The following is a description of a gene set: studied in species Homo sapiens from publication Chen Y, Wang X (PMID 31504780) Human Gene Set: MIR4772_5P Genes predicted to be targets of miRBase v22 microRNA hsa-miR-4772-5p in miRDB v6.0 with MirTarget v4 prediction scores > 80 (high confidence targets)., and this is the list of marker genes: KBTBD4, ABT1, GAS2L3 (NCBI Gene Id 283431, growth arrest specific 2 like 3), FOS, SV2B, SLITRK4, KLHDC10, APP, SLC37A3, FUS, VCP, DUS4L, CNOT4, RBM20, GTDC1, KDELR3 (NCBI Gene Id 11015), MAL2, ENDOV, WAC, ZNF316, CALD1, RPL31, PHACTR3, AFAP1L1, STK40, ZMAT4, DBR1, LRBA, ANKRD34C, HNRNPH1, PRUNE1, GPX8, TTC1, IQSEC2, ZNF780A, ANTXR1, HSPA13, SLC39A3, WIPF2, FREM1, OR11A1, NCKAP1, F8, OGFOD1, ITGA9, AKAP12, RCAN2, EDARADD, IDO2, ASB3, YLPM1, CELF3, KRT10-AS1